Given this list of marker genes MBOAT2, LPGAT1, PLA2G2F, PLA2G4C, PLAAT3, PLAAT4, MBOAT1, LPCAT4, PLA2G4B, LPCAT3, ABHD4, PLAAT2, here is a description of the gene set: Human Gene Set: GOBP_PHOSPHATIDYLETHANOLAMINE_ACYL_CHAIN_REMODELING studied in species Homo sapiens Remodeling the acyl chains of phosphatidylethanolamine, through sequential deacylation and re-acylation reactions, to generate phosphatidylethanolamine containing different types of fatty acid acyl chains.